Given this list of marker genes EYA4, UBE2N, H4C9, H4C1, H2BC17, KDM4B, ABRAXAS1, KAT5, UBXN1, PIAS4, EYA3, UIMC1, BRCA1, H4C4, KDM4A, H2BC3, H2BC1, MRE11, H2BC14, MAPK8, TP53 (NCBI Gene Id 7157, tumor protein p53), ATM, H4C12, ABL1, H2BC4, APBB1, SUMO1, UBC, H4C15, H2BC7, H2BC9, MDC1, TP53BP1, H4C13, BAP1, H4C3, UBE2I, BRCC3, H4C6, RNF8, H4C2, H2BC21, H2BC10, H2BC26, H4C5, H4C8, H2BC12L, RAD50 (NCBI Gene Id 10111), NSD2, BABAM1, RPS27A, H4C16, H2BC15, UBA52, UBB, H2BC5, EYA2, UBE2V2, H3-4, NBN, CHEK2, H2AX, PPP5C, H2BC8, HERC2, H2BC11, EYA1, H2BC12, BAZ1B, BABAM2, RNF168, KPNA2, H4C11, H2BC6, H4C14, SMARCA5, H2BC13, BARD1, here is a description of the gene set: species: Homo sapiens DNA Double Strand Break Response Human Gene Set: REACTOME_DNA_DOUBLE_STRAND_BREAK_RESPONSE